The following is a description of a gene set: from publication Gavish A, Tyler M, Greenwald AC, Hoefflin R, Simkin D, Tschernichovsky R, Galili Darnell N, Somech E, Barbolin C, Antman T, Kovarsky D, Barrett T, Gonzalez Castro LN, Halder D, Chanoch-Myers R, Laffy J, Mints M, Wider A, Tal R, Spitzer A, Hara T, Raitses-Gurevich M, Stossel C, Golan T, Tirosh A, Suvà ML, Puram SV, Tirosh I (PMID 37258682) In this study, an extensive analysis was conducted to define meta-programs (MPs) capturing intra-tumor heterogeneity across a spectrum of tumor types. The approach utilized non-negative matrix factorization (NMF) to analyze each cell type separately within individual tumor samples. This involved the analysis of malignant cells, macrophages, fibroblasts, endothelial cells, epithelial cells, T-cells, and B-cells. NMF was executed with varying parameter values (K=4, 5, 6, 7, 8, 9), thereby generating 39 programs for each cell type per sample. Each NMF program was summarized by the top genes based on NMF coefficients.\nRobust MPs were then delineated for each cell type using a set of stringent criteria, including recurrence within the same tumor, similarity to programs in other tumors, and non-redundancy within a tumor. Subsequently, these robust NMF programs were clustered (per cell type) based on Jaccard similarity, leading to the identification of MPs associated with each cell type.\nTo enhance the quality of the MPs, a refinement steps were undertaken, involving the removal of MPs suspected of reflecting low-quality data (with an overrepresentation of ribosomal proteins or mitochondrial-encoded genes), single-study inclusion, or similarity to miss-annotated cell types. Human Gene Set: GAVISH_3CA_METAPROGRAM_CD4_T_CELLS_T_REG studied in species Homo sapiens Genes upregulated in subsets of cells of a given type within various tumors, and this is the list of marker genes: UCP2, RTKN2, CXCR6, CD7, NAMPT, LGALS1, BATF, IL2RB, PHLDA1, IL2RA, TNFRSF4, SYNGR2, TBC1D4, SAT1, CARD16, TNFRSF1B, TNFRSF18, IFI6, ACP5, GLRX, PKM (NCBI Gene Id 8127), TIGIT, CTSC, IL1R2, TYMP, GBP2, GBP5, LTB, BTG3, LAYN, CASP1, GADD45A, DUSP4, DNPH1 (2'-deoxynucleoside 5'-phosphate N-hydrolase 1), CD27, ICOS, CTLA4, CORO1B, PIM2, HLA-DRB1, LAIR2, MAGEH1, MIR4435-2HG, PMAIP1, ARID5B, FOXP3, UGP2, CST7, TNFRSF9